The following is a description of a gene set: Human Gene Set: GOMF_BETA_GALACTOSIDE_CMP_ALPHA_2_3_SIALYLTRANSFERASE_ACTIVITY Catalysis of the reaction: CMP-N-acetylneuraminate + beta-D-galactosyl-(1->3)-N-acetyl-alpha-D-galactosaminyl-R = CMP + alpha-N-acetylneuraminyl-(2->3)-beta-D-galactosyl-(1->3)-N-acetyl-alpha-D-galactosaminyl-R. species: Homo sapiens, and this is the list of marker genes: ST3GAL5, C20orf173, ST3GAL1, ST3GAL3, ST3GAL6, ST3GAL4, ST3GAL2